The following is a description of a gene set: Mouse Gene Set: GOBP_RETINAL_BIPOLAR_NEURON_DIFFERENTIATION studied in species Mus musculus The process in which a relatively unspecialized cell acquires specialized features of a bipolar cell, the last neuron to be generated in the retina., and this is the list of marker genes: Naglu, Vsx2, Irx6, Zhx2, Bbs10, Ndp, Gnat2, Casz1, Bhlhe22, Prdm1, Vsx1, Irx5 (Iroquois homeobox 5), Ikzf1, Cabp4, Rho